Given this list of marker genes Tas2r120 (NCBI Gene Id 387348), Scnn1a, Tas2r126, Tas2r105, Tas2r136, Tas2r139, Gnat3, Gnb3, Tas2r108, Tas2r119, Tas1r2, Tas2r121, Tas2r130, Tas2r118, Tas2r144, Scnn1b, Tas1r3, Tas2r137, Scnn1g, Tas2r138, Tas2r107, here is a description of the gene set: species: Mus musculus This event has been computationally inferred from an event that has been demonstrated in another species.<p>The inference is based on the homology mapping from PANTHER. Briefly, reactions for which all involved PhysicalEntities (in input, output and catalyst) have a mapped orthologue/paralogue (for complexes at least 75% of components must have a mapping) are inferred to the other species. electronically inferred by orthology from the curated human pathway part of: Sensory Perception Reactome Pathway: Sensory perception of taste